The following is a description of a gene set: species: Mus musculus Any process that results in a change in state or activity of a cell (in terms of movement, secretion, enzyme production, gene expression, etc.) as a result of an interleukin-2 stimulus. Mouse Gene Set: GOBP_CELLULAR_RESPONSE_TO_INTERLEUKIN_2, and this is the list of marker genes: Il2rb, Il2rg, Stat5a, Stat3, Jak3, Il2ra, Jak1, Flicr, Ptpn2, Il2